Given this list of marker genes PSMD12, USP11, PSMA7, USP13, USP8, PSMC3 (NCBI Gene Id 96121), USP14, PSME1, PSMB4 (proteasome 20S subunit beta 4), PSME3, FBXO21, SIAH2, PSMB10 (NCBI Gene Id 8138), UBE2T, SIAH1, PSMD1, PSMD10, PSMD14, UBE2R2, UBE2Q2, USP18, UBE2D2, PSMA1, USP25, USP46, UBR7, USP10 (NCBI Gene Id 9100), PSMA4, PSMC5, UBA6, SQSTM1, UBE2G1, CDC20, UBE2C, PSMD3, UCHL3, UBE3A, PSMB2, UBA3, PSMD8, PSMB3, ARIH1, PSMA5, USP39, USP4, PSMB8, USP32P2, PSMB6, CDC34, USP1, here is a description of the gene set: Genes that comprise the proteasome gene module A major goal of cancer research is to match specific therapies to molecular targets in cancer. Genome-scale expression profiling has identified new subtypes of cancer based on consistent patterns of variation in gene expression, leading to improved prognostic predictions. However, how these new genetic subtypes of cancers should be treated is unknown. Here, we show that a gene module map can guide the prospective identification of targeted therapies for genetic subtypes of cancer. By visualizing genome-scale gene expression in cancer as combinations of activated and deactivated functional modules, gene module maps can reveal specific functional pathways associated with each subtype that might be susceptible to targeted therapies. We show that in human breast cancers, activation of a poor-prognosis wound signature is strongly associated with induction of both a mitochondria gene module and a proteasome gene module. We found that 3-bromopyruvic acid, which inhibits glycolysis, selectively killed breast cells expressing the mitochondria and wound signatures. In addition, inhibition of proteasome activity by bortezomib, a drug approved for human use in multiple myeloma, abrogated wound signature expression and selectively killed breast cells expressing the wound signature. Thus, gene module maps may enable rapid translation of complex genomic signatures in human disease to targeted therapeutic strategies. Human Gene Set: WONG_PROTEASOME_GENE_MODULE from publication Wong DJ, Nuyten DS, Regev A, Lin M, Adler AS, Segal E, van de Vijver MJ, Chang HY (PMID 18199530) species: Homo sapiens